The following is a description of a gene set: Human Gene Set: GOBP_POLYOL_BIOSYNTHETIC_PROCESS The chemical reactions and pathways resulting in the formation of a polyol, any alcohol containing three or more hydroxyl groups attached to saturated carbon atoms. studied in species Homo sapiens, and this is the list of marker genes: SNCA, ITPKC, PPIP5K2, GPER1, CYP27B1, P2RY6, IPMK, SPHK1, IMPA2, PRKG1, QDPR, NTSR1, PTH1R, PCBD2, PPIP5K1 (NCBI Gene Id 9677), CYP24A1, DHFRP1, ITPKB, ASAH1, AVPR1B, PTAFR, CYP27A1, IPPK, SPTSSA, SPTLC2, DHFR, PCK1, P2RY1, IMPA1, ABCA2, ACER3, PLCG2, IP6K3, GOT1, ISYNA1, PTH, PGP, CD244, PTS, GBA1 (glucosylceramidase beta 1), PLEK, ACER1, GCH1, IP6K2, AGK, ADCYAP1R1, CYP3A4, ASAH2, PCK2, LHCGR, CYP2R1, SCP2, SPHK2, SPTLC1, ITPKA (NCBI Gene Id 3706), ACER2, SPTSSB, IP6K1, SPR, LEP (NCBI Gene Id 3952), PCBD1, SPTLC3